The following is a description of a gene set: Urethral valve species: Homo sapiens The presence of an abnormal membrane obstructing the urethra. Human Gene Set: HP_URETHRAL_VALVE, and this is the list of marker genes: CHRM3, SRCAP, SALL1, HNRNPH1, MID1 (NCBI Gene Id 8230), APC2 (NCBI Gene Id 10297), HPSE2 (heparanase 2 (inactive)), NSD1, BNC2, IGF2, DACT1